Given this list of marker genes Myl9, Nf2, Pak2, Cdc42, Myl6, Myh11, Calm3, Rac1, Ppp1r12a, Pak3, Pak1, Limk1, Flna, Ppp1cb, Myh14, Ppp1r12b, Mylk, Calm2, Myh9, Calm1, Myl12b, Myh10, here is a description of the gene set: studied in species Mus musculus Mouse Gene Set: REACTOME_RHO_GTPASES_ACTIVATE_PAKS RHO GTPases activate PAKs